The following is a description of a gene set: Human Gene Set: MIR6868_3P from publication Chen Y, Wang X (PMID 31504780) Genes predicted to be targets of miRBase v22 microRNA hsa-miR-6868-3p in miRDB v6.0 with MirTarget v4 prediction scores > 80 (high confidence targets). studied in species Homo sapiens, and this is the list of marker genes: CAMSAP2, WDR89, ZNF367, FRYL, VANGL1, CTLA4, PLP1, ADGRF5, ZSWIM6, SORBS1, FAM13C, ANTXR2, RBM27, STK3, SIGLEC1, KCNB1, NEGR1, NIPBL, NAV1, MLEC, PARD3B, CLDN11, ABLIM1, SOX4, PRKG2, GPRIN3, PTPMT1, CDK2, DPYSL3, VWC2, DUSP7, UBA6, DECR2, CPSF6, ANKRD13C, PLCXD3, MCIDAS, NFIB (nuclear factor I B), DEFA6, PRDM1, TMEM132B, WWC3, LHFPL3, ZNF287, MMUT, GADD45A, PROSER2, AAK1, ZFP36L1, ERP29, ATF3, HRH1, CETN3, KIFC3, SMIM14, CHN1, CROT, TDRD1, FRMD6, DPH3P1 (diphthamide biosynthesis 3 pseudogene 1), GPR68, AP1G1, LSAMP, MECP2, KLRK1, ZHX2, TNRC6B, SMARCD1, RASSF5, STIM2 (NCBI Gene Id 57620), RAPGEF4, BCL6, GCNT2, C6orf136, TNS1, POLG, B3GNT5, KPNA6, CORO2A, CD81, RO60, LINC03042, ASTN1, SLC2A12, HECW1, KPNA1, EEF1A1, RAB3IP, MTCL3, WBP1L, TSKU, BTBD3, SESN3, SLC35A3, SLC5A3, G3BP2, FGFBP3, TIMP3, EIF4E, KTN1, TRPM8, RPS6KA3, RFX3, FBXO32 (F-box protein 32), CCDC172, ACSM2A, PDE4C, CDK19, DEPDC4, APLF, NLGN1, TFDP2, PZP, TSHR, ZDBF2, FOXC1, DUSP18, AGPAT4, PUS7L, CLCN3, SP140 (SP140 nuclear body protein), DENND4A, TECPR2, DNAJA2, TOM1L1, TNFAIP8, ALKBH8, ANKS6, RNF138, PIK3R5, ERBB4 (NCBI Gene Id 2066), LDLRAD4, DNAJC25-GNG10, DGAT2, TAOK3, AXIN2, EIF4E3, ZNF404, YY2, SRP19, FERMT2, LRRTM4, GALNT15, TFAP2B, RBM47, GPR26, FXN (NCBI Gene Id 2395), ATP2A1, RAB5A, ZNF737, BCL6B (NCBI Gene Id 7613), C6orf141, METAP2, ZBTB41, ZMAT1, PLA2G15, TMEM248 (NCBI Gene Id 55069), KIAA1549 (KIAA1549), DCAF7, OTULINL, CFAP97, CAPRIN1, CCNJ, LMLN, PIP5K1A, RFX7, EIF1AX, EVA1C, FOXN3, EHF, SLC7A6, RUNX2, DENND1A, ID2, LINC01517, GATA2, NFAT5, DDC (NCBI Gene Id 9492), RREB1, SLC39A8, MARCKS, ELK3, SV2B, TMEM95, C11orf97, RASAL2, ILDR2, PRKDC, ZC3H12B, ENC1, TTC7B, C1orf74, CNTNAP2, TMEM273, ARRDC3, SELENOK, RBM41, EPDR1, ZEB1, CRTC3 (NCBI Gene Id 64784), CHM, CACNA1B, STEEP1, GNG10, ZNF670, MAP3K13 (NCBI Gene Id 9175), NOX4, TIMM10B, SGCD, ZHX1, FYTTD1, C9orf57, CDKN2AIP, LTA, NUDT12, PRKCA, SHROOM4, PHF6, CLCN5 (NCBI Gene Id 90056), CHRM2, KY (NCBI Gene Id 339855), CRTAP, POGZ, AP1AR, DNAH5, RAB3C, GXYLT1 (glucoside xylosyltransferase 1), PIK3CA, C1orf115, NOL7, NOTCH2NLA, THSD4, MYO5B, EPHA5, SYCE1, NAALAD2, COL4A6, FRK, CDH11, FGF1, SEL1L (NCBI Gene Id 6400), PGGT1B, CA8, PTPRM, LYN, POU2F1, SLIT3, DNM3, SMAD2, RBFOX1, PDK4, CLMP, ARID1B, CCND2, ZC3HC1, ACAN, NALF1, SEPTIN9, ARHGEF26, KMT2A, VCL, DCLK1, APLN, CPEB2, SPART, PLG, MS4A15, BAG4, RLIM (ring finger protein, LIM domain interacting), PDE3A, ONECUT2